The following is a description of a gene set: studied in species Homo sapiens Human Gene Set: GSE13887_RESTING_VS_NO_TREATED_CD4_TCELL_UP from publication Fernandez DR, Telarico T, Bonilla E, Li Q, Banerjee S, Middleton FA, Phillips PE, Crow MK, Oess S, Muller-Esterl W, Perl A (PMID 19201859) Genes up-regulated in CD4 T cells from healthy donors: resting versus nitric oxide. CD3-positive T cells were negatively isolated from 10 SLE patients and 9 healthy controls without SLE. All of the SLE samples and control samples were compared with one another to identify baseline differences in expression due to the disease. Next, T cell preparations from 4 of the control subjects were stimulated with either Nitric Oxide (NOC-18) 600 uM for 24hr or stimulated through CD3/CD28 for 24hr to determine which genes were responsive to these signaling mechanisms. Here, we show that activity of the mammalian target of rapamycin (mTOR), which is a sensor of the mitochondrial transmembrane potential, is increased in SLE T cells. Activation of mTOR was inducible by NO, a key trigger of MHP which in turn enhanced the expression of HRES-1/Rab4, a small GTPase that regulates recycling of surface receptors through early endosomes. Expression of HRES-1/Rab4 was increased in SLE T cells and, in accordance with its dominant impact on the endocytic recycling of CD4, it was inversely correlated with diminished CD4 expression. HRES-1/Rab4 over-expression was also inversely correlated with diminished TCRζ protein levels. Combined with follow up studies, these results suggest that activation of mTOR causes the loss of TCRζ in lupus T cells through HRES-1/Rab4-dependent lysosomal degradation., and this is the list of marker genes: CCT6B, APLNR, MIR211, BMP8A, GABRD, CDR2L, TMEM168, ADAMTS7, GPR151, LRRTM1, SLC5A7, CER1, TNS4, SESTD1, SYP, KRTAP6-3, SPATA17, GCGR, ZBTB14, RALYL, UPRT, RABIF, PI4KA, HRC, LRRC2 (NCBI Gene Id 82953), SEC24C, SCARF1, PHYHD1, JAG2, FGF13, FGG, HDGFL1, KRT86, DUOX2, HGD, RFX6, DPYSL4, GGCX, TLR8, KRTAP1-5, CAMSAP1, DIO1, CMTM5, CLEC11A, ZSCAN22, KIR3DL2, KCNJ9, ACTR2, IDO1, PCDHB4, ERMP1, PROK2, SLC12A1, UHMK1, OCIAD2, SYCN, GRPEL2, PRODH, KCNT1, SFXN2, USH2A, POMGNT2, MCOLN1, SEC16B, CEP250, KRTAP24-1, NUDT12, MIR183, KCNC2, TRPM1, FAM3A, ADARB2, ECSCR, STRA8, KCNIP2, VNN3P, KRT15, MIR338, MRAP2, FZD3, CYP4X1, TRH, SLC25A41, SMPX, COL6A4P1, HCRTR1, FOXD4 (forkhead box D4), SLC17A1, MIR34C, SIGLEC5 (NCBI Gene Id 8778), PRR18, ZFP14, TFPI2, MIR194-1, SLC38A5, MTFMT, CBX1, APOF, FBXO27, OLFM2, ZFP2, BRINP1, MAPK4, DUSP13B, FFAR1, NHLRC4, ADCY2, MIR7-2, PFN4, PKHD1, HTR5BP, ADAMTS20, GNAT2, XCR1, CNTN3 (NCBI Gene Id 57632), CMKLR1, ENO4, CCM2L, MIRLET7B, NTNG1, ZBTB7C, SLC44A3, CYP7B1, PLXNA2, DPYSL3, SRPX2, MIR184, PBLD, SERPINA10, STYXL2, CFAP65, TTC39B, SLC34A1, SRL, SLC5A8, LBX2, SYTL5, ASPG, IL19